Given this list of marker genes CYP2C9, CYP2F1, CYP2A6, CYP2A13, CYP2D6, CYP2E1, CYP2A7, CYP2S1, CYP2C8, CYP2B6, CYP2C19, here is a description of the gene set: studied in species Homo sapiens Human Gene Set: REACTOME_CYP2E1_REACTIONS CYP2E1 reactions